Given this list of marker genes Nsun5, Tmed8 (NCBI Gene Id 76230), Pramel3e, Tmem260, Tmem64, C2cd2 (NCBI Gene Id 74759), Fancc, 1700025G04Rik, Tmem72, Selenop, Dcdc2a, Prkg1, Zfp606, Pik3ca, Bptf, Ank, Aasdhppt, Ugcg, Rbm7 (RNA binding motif protein 7), Rtn4rl1, Chsy3, Mab21l2, Map7, Zfp148, Homer1, Nupr2, Zfp983, Slc6a15, Pramel3c, Mtmr3, Lyg1, Nudt2, Hhip, Dcx, Ube2f, Dach1, Gata2, Fundc2, Efnb2, Atp6v1g3, Foxj3 (NCBI Gene Id 230700), Pgrmc2, Tbck, Kidins220, Pramel3b, Tlk1, Racgap1, Tcf12, Pramel3a, Hecw1, Prrx1, Klhl9, Nlrp6, Egln3, Pank2, Man1a2, Pias2, Ormdl2, Slc35f1, Spop, Mamdc2 (NCBI Gene Id 71738), Pde1c, AU040320, Myt1l, Zfp62, Bloc1s4, Pclo, Fam168a, B3galnt1, Npr3, Snapc4, Gpr158, Pcdh15, Zeb1, Reps2, Mageb5b, Rapgef5, Senp6, Akr1c20, Wdr55, Sulf1, Slc40a1, Acaca, Tmem33, Lrrc34, Chrdl1, Cd226, Tiparp, Cep350, Fbxl5, Acp3, Kcnma1, Gad1, Lrit1, Zcchc13 (NCBI Gene Id 75064, zinc finger, CCHC domain containing 13), Mtcl2, Ralgapb, Camk1d, Fancl, Ntrk2, Ssbp2, Zfp696, Gpr83, Tmod2, Tssk4, Capn6, Zfhx4, Il6ra, Apob, Septin6, Arrdc3, Smyd4, Oxct1, Dlg5, Khsrp, Tatdn1, here is a description of the gene set: Mouse Gene Set: MIR_6400 Genes predicted to be targets of miRBase v22 microRNA mmu_miR_6400 in miRDB v6.0 with MirTarget v4 prediction scores > 80 (high confidence targets). studied in species Mus musculus from publication Chen Y, Wang X (PMID 31504780)